The following is a description of a gene set: Genes predicted to be targets of miRBase v22 microRNA mmu_miR_28b in miRDB v6.0 with MirTarget v4 prediction scores > 80 (high confidence targets). species: Mus musculus from publication Chen Y, Wang X (PMID 31504780) Mouse Gene Set: MIR_28B, and this is the list of marker genes: Clrn1, Gprc5a, Zfp503, Lrrc66, Abraxas2, Rnf41, Ncan, Fbxl18, Asxl2, Snu13, Dnajc16, Ldlrad3, Ucn2, Atg9b, Cdk7, Stk26, Krtap24-1, Iffo2, Kcna2, Alkbh1, Esrrg, Hyal1 (NCBI Gene Id 15586), Trmt112 (tRNA methyltransferase 11-2), Osbpl6, Akirin1, Vcf1, Aste1, H2-Q10, A830018L16Rik, Ccr1, 2700062C07Rik, Cracd, Map3k3, Kmt2a, Sh2d3c, Fam169b, Bmp15, Eef2k, Cstpp1, Tpcn2, Glcci1, Pcdh10